Given this list of marker genes Ap3b1, Ap3s2, Ap3b2, Ap3d1, Ap3m2, Ap3m1, Ap3s1, here is a description of the gene set: species: Mus musculus Mouse Gene Set: GOBP_CLATHRIN_COATED_VESICLE_CARGO_LOADING Formation of a macromolecular complex between the cytoplasmic coat proteins on clathrin-coated vesicles and proteins and/or lipoproteins that are going to be transported by a vesicle.